The following is a description of a gene set: studied in species Mus musculus Mouse Gene Set: REACTOME_CYCLIN_A_CDK2_ASSOCIATED_EVENTS_AT_S_PHASE_ENTRY Cyclin A:Cdk2-associated events at S phase entry, and this is the list of marker genes: Psmb3, Akt2, Wee1, Uba52, Psmd12, Psmc3, Psma2, Cdkn1a, Psmb4, Psma1, Psmb6, Cul1, Cdk7, Cdc25b (NCBI Gene Id 99033), Psmd8 (proteasome (prosome, macropain) 26S subunit, non-ATPase, 8), Psma7, Ubc, Psmc6, Psmb1, Fzr1 (NCBI Gene Id 56371), Skp1, Psmd14, Psma5, Skp2, Psmd7, Ccnd1, Ccnh, Cdkn1b, Psmc4, Akt1, Psma6, Psmc2, Psma3, Psmc5, Cables1, Cdc25a, Psmc1, Ccne2, Cdk4, Uba52rt, Mnat1, Cks1b, Cdkn1c, Cdk2, Psmd2, Psmd13, Akt3 (thymoma viral proto-oncogene 3), Psmd11, Psmb7, Ccna2 (NCBI Gene Id 99481), Rps27a, Psmd3, Ccna1, Ccne1, Ptk6 (PTK6 protein tyrosine kinase 6), Ubb, Psmd1, Adrm1, Psma4, Psmb5, Psmd6, Psmb2, Rb1